Given this list of marker genes NUP58, DHX32, SEPTIN10, PTGER2, CEP44, FRMPD3, SRP72, TGFBR1, TAPT1, UPF3B, KIAA0513, LUM, ZNF268, TRAFD1, PRX, TEAD1, BICD2, SDC2, ZNF267, ADGRG6, USP2, PLEKHA8, SPDYE1, PHF21A, EPB41L4B, MPLKIP, FOXJ3, RARS2, POLI, SUPT20H, ATP1B2, TMEM106B, STRAP, TRAF3, CPLX2, RAB5A, TNFRSF17, POU2AF2, ATP1A3, HOXC8, NME5, PTEN, ISCU, TUBGCP5, RNF217, NR3C1, EDDM3A, TBC1D12, PPP2CA (NCBI Gene Id 5515), RAD51B, ZKSCAN8, CMTM6, RSBN1L, TEX2, ANKFY1, FBXO33, PKN3, NFYB, SEMA3D, EYA1, CRTAP, TBL1X, MMGT1, MOBP, ZNF287, SPRTN, DAD1, CLK4, SLC38A9, SAP130, PRKAB2, AREL1, MCF2, FABP3, GPR34, TMEM139, ORC2, WDFY3, ZNF548, ILDR2, PTGFR, INA, MYO5A, RYBP, UBE2V2, ADTRP, SHISAL1, here is a description of the gene set: studied in species Homo sapiens from publication Chen Y, Wang X (PMID 31504780) Human Gene Set: MIR6730_3P Genes predicted to be targets of miRBase v22 microRNA hsa-miR-6730-3p in miRDB v6.0 with MirTarget v4 prediction scores > 80 (high confidence targets).